The following is a description of a gene set: Visible space between the dental arches in occlusion. Open bite studied in species Homo sapiens Human Gene Set: HP_OPEN_BITE, and this is the list of marker genes: ROR2, NXN, PRKAR1A, GPR68, NOTCH2, ARSK, NCF1, RAI1, PTEN, TWIST1, GTF2I, BMP2, POLR1C, ENAM (enamelin, NCBI Gene Id 200), BAZ1B, STX1A, PDE4D, CUL4B, METTL27, OFD1, GTF2IRD2, MMP20, RUNX2 (NCBI Gene Id 860), FZD2, KCNH1, SOBP, ELN, TCOF1, CLIP2, ATP6V1B2, DVL3, KCNN3, OCRL, BMP4, GNAI3, HNRNPK, PORCN, ITGB6, ADAMTS2, DNAJC30 (NCBI Gene Id 84277, DnaJ heat shock protein family (Hsp40) member C30), TBL2, FGFR2, AMELX, LIMK1, BUD23, POLR1B, VPS37D, TMEM270, FAM83H, DSPP, DVL1, EIF4H, KLK4, FGFR3, FKBP6, WNT5A, BRAF, POLR1D, RFC2, HNRNPH1, GTF2IRD1, RELT